Given this list of marker genes PIP4K2A, ATP1B1, CLSTN1, TRIM33, DAB1, CCN1, HLX, CDC42, PPP2R5A, ST7L, YY1AP1, RRAGC, MAN1C1, UBQLN4, PRPF38A, GFI1, CNTN2, IPO9, GNG4, GATA3, SORT1, ZNF32, KANK4, MPC2, STMN1, HIPK1, RABIF (RAB interacting factor), PLK3, SRRM1, UQCRH, NBPF11, COMMD3, SFT2D2, COL13A1, USP48, C1orf43, ADIPOR1, SMAP2, PCGF5, TLCD4, BMI1, VDAC2, ZMYM4, PUM1, HMGN2, POU2F1, GPR161, ARHGAP12, SZT2, HNRNPR, ORC1, FAM13C, WAC, FBXO2, ADGRL2, TPM3, SZRD1, RBBP4, PDIK1L, RNF19B, TXNIP, ODR4, MYCL, ATXN7L2, PRKACB, AGO1, MACO1, UROD, CAPZA1, USP1, SCMH1, TPR, SNX27, NSUN6, RSBN1, PIGV, RCC2, H6PD, DHCR24, C1orf21, ZBTB8OS, CDC14A, PRDM16, ZCCHC17 (NCBI Gene Id 95373), POU3F1, DR1, RNF207, UBE4B, ANP32E, ZFYVE9, USF1, RGS7, ATPAF1 (NCBI Gene Id 64756), NCDN, HPCA, PLD5, ADGRB2, FAM76A, MAST2, PPP1R12B, LMX1A, CDC73, MAGI3, MPZL1, DAP3, SDCCAG8, TFAP2E, ZNF644 (NCBI Gene Id 90858), NTRK1, CSDE1, SYT6, GRIK3, COP1, DDAH1, SFPQ, PMEL, EIF2B3, PKN2, ZNF281, ARHGEF10L, ZNF503, KCND3, MARCKSL1, ZNF362, SUV39H2, TINAGL1, CSRP1, APH1A, DDX50, VAMP3, LRRC41, PABPC4, RNF2, KIF17, MAPKAPK2, VPS26A, NIBAN1, ADO, PUSL1, CCDC6, KCNQ4, SLC25A16, HTR7, ZBTB48, HECTD2, RLF, LCK (LCK proto-oncogene, Src family tyrosine kinase), TAL1, PTF1A, POGZ, SNRNP40, EFNA3, FBXO44, B4GALT2, FOXD3, MED8, PPM1J, LAMTOR2, AK3, NEGR1, RASGEF1A, PIK3R3 (phosphoinositide-3-kinase regulatory subunit 3), PHYHIPL, CAP1, DNAJB12, CMPK1, EPHB2, SLC4A2, CELSR2, KIF1B, WNT9A (Wnt family member 9A), LRP8, FAM43B, AKR7L, CSGALNACT2, GNB1, CTNNBIP1, MYCBP, SERBP1, YTHDF2 (NCBI Gene Id 63042), here is a description of the gene set: Human Gene Set: E2F_Q2 Genes having at least one occurrence of the motif GGCGSG in the regions spanning 4 kb centered on their transcription starting sites. This matches the E2F, TFDP1 transcription factor binding site V$E2F_Q2 (v7.4 TRANSFAC). studied in species Homo sapiens